Given this list of marker genes Adamts19, Pitx2, Bmpr2, Axin2, Zfpm2, Twist1, Gata4, Olfm1, Heyl, Ccn1, Bmpr1a, Slit3, Zfpm1, Smad6, Notch1, Gja5, Naglu, Mdm2, Efna1, Tbx5, Sox4, Acvr1, Hey1, Tgfbr2, Dchs1, Bmp2, Tgfb2, Hey2, Aplnr, Tbx20, Smad4, Mdm4, Lix1l, here is a description of the gene set: studied in species Mus musculus Mouse Gene Set: GOBP_ATRIOVENTRICULAR_VALVE_DEVELOPMENT The progression of the atrioventricular valve over time, from its formation to the mature structure.